Given this list of marker genes Serpina6, Hsd3b1 (hydroxy-delta-5-steroid dehydrogenase, 3 beta- and steroid delta-isomerase 1), Hsd3b9, Cyp17a1, Hsd3b6, Hsd11b1, Hsd3b2, Cyp21a1, Hsd11b2 (hydroxysteroid 11-beta dehydrogenase 2), Hsd3b8, Cyp11b2, Pomc, Hsd3b5, Hsd3b3, Cyp11b1, Hsd3b4, here is a description of the gene set: Mouse Gene Set: REACTOME_GLUCOCORTICOID_BIOSYNTHESIS studied in species Mus musculus Glucocorticoid biosynthesis